Given this list of marker genes INPPL1, EBP, SHC1, SOS2, AKT1, CREB3 (cAMP responsive element binding protein 3), PTK2, RPS6KB1, IRS1 (insulin receptor substrate 1), RPS6KA2, RPS6KA3, IGFBP1, SOS1, PAK6, GADD45A, YWHAQ, PIK3R5, PREX1 (NCBI Gene Id 57580), PARD6A (par-6 family cell polarity regulator alpha), MTOR, PAK4, MYC, PAK5, CDKN1B, PPP1R13B, AKT3, SLC2A4, NOLC1, PDPK1, PTPN1, MET, YWHAZ, GRB2, YWHAH, PIK3CA, BAD, CDKN2A, CREB5, F2RL2, IRS4, CREB1, CDC42, PAK1, TSC2, PIK3CD, SFN, FOXO3, GSK3B, PAK2, IGF1, YWHAG, BCL2L1, IFI27, AKT2, GSK3A, TSC1, IRS2, RPS6KA1, PAK3, CYTH3, ERBB4, YWHAB, CDK2, GAB1, YWHAE, PTEN, PARD3, here is a description of the gene set: Human Gene Set: SIG_PIP3_SIGNALING_IN_CARDIAC_MYOCTES Genes related to PIP3 signaling in cardiac myocytes studied in species Homo sapiens